The following is a description of a gene set: studied in species Homo sapiens Human Gene Set: GOBP_FRUCTOSE_1_6_BISPHOSPHATE_METABOLIC_PROCESS The chemical reactions and pathways involving fructose 1,6-bisphosphate, also known as FBP. The D enantiomer is a metabolic intermediate in glycolysis and gluconeogenesis., and this is the list of marker genes: PFKP, FBP1, ALDOA, ALDOB, PFKL, IFNG, ALDOC, FBP2 (NCBI Gene Id 8789), PFKM (NCBI Gene Id 5215)